Given this list of marker genes TBP (TATA-box binding protein), NR4A2, MT-TT, SNCA, ADH1C, LRRK2, ATXN8OS, FBXO7, ATXN3, SNCAIP, PRKN (NCBI Gene Id 8004), GBA1, MAPT, ATXN2, here is a description of the gene set: Substantia nigra gliosis Human Gene Set: HP_SUBSTANTIA_NIGRA_GLIOSIS Focal proliferation of glial cells in the substantia nigra. studied in species Homo sapiens